The following is a description of a gene set: During acute viral infections, naïve CD8+ T cells differentiate into effector CD8+ T cells and, after viral control, into memory CD8+ T cells. Memory CD8+ T cells are highly functional, proliferate rapidly upon reinfection and persist long-term without antigen. In contrast, during chronic infections, CD8+ T cells become “exhausted” and have poor effector function, express multiple inhibitory receptors, possess low proliferative capacity, and cannot persist without antigen. To compare the development of functional memory T cells with poorly functional exhausted T cells, we generated longitudinal transcriptional profiles for each. Human Gene Set: GSE41867_DAY8_VS_DAY15_LCMV_ARMSTRONG_EFFECTOR_CD8_TCELL_DN studied in species Homo sapiens from publication Doering TA, Crawford A, Angelosanto JM, Paley MA, Ziegler CG, Wherry EJ (PMID 23159438) Genes down-regulated in CD8 T effectors at acute infection with LCMV-Armstrong: day 8 versus day 15., and this is the list of marker genes: ORM1, CNTFR-AS1, SLITRK1, KIF20A, PPFIA4, TAC4, SBK1, CGN, APOBEC2, IMPG1, IL23R (interleukin 23 receptor), AHCTF1, CCDC144BP, TDRG1, TMEM169, WDR97, TNKS, FOXF1, MBD3L2 (methyl-CpG binding domain protein 3 like 2), GMNC, TBX3, APLN (apelin), CUBN, TMEM51-AS1, DYDC1, KHDC3L, TRIM52, AQP10, LINC02223, LINC01015, IDO2, FBXO41, SPACA3 (sperm acrosome associated 3), ZFP1, ENTPD3, GJA4, ENSG00000284837, PHC1, LINC00221, ANKRD30BP2, C15orf32, TMPRSS11B, MBD3L1, FMN2, TLK2, MID1, LINC01056, ANKRD28, WFDC1, ANKFN1, PAK5, PAK3, MARCHF8, POU4F1 (NCBI Gene Id 730659), ANKRD26, VPS37D, ESRRB, KIF17, KLRG2, LINC01555, INKA2-AS1, C11orf52, ROR1, LINC00592, KRTAP2-4, CDKN3, C19orf81, TXK, FLJ30679, SLC25A2, LINC01020, SERPINA3, L1CAM, ZIC5, ANKS6, SNORD123, SCGB2A1, KCNA1, GRIK1, PRRX1, DIRC3, CDH18, ENSG00000176984, ZNF385D, CHTF18, LINC01278, ASPA, PRKCE, MTPN, ENSG00000124835, SLC6A1, FGF5, NRARP, ABCC2 (NCBI Gene Id 1244), PCCA, PDK3, KCNQ1DN, KLF17, TNFRSF19, DNA2, GLDC, ICAM5, MIR205HG, ZRANB1, GARIN1A, DCAF12, TTR, ENSG00000224090, LINC00310, H3C1, INSYN2A, POGLUT2, KLHL34, H2AC11 (H2A clustered histone 11), RCVRN, PPP1R36, CRYBB3, STRC, EFCAB3 (NCBI Gene Id 146779), VAT1L, AKR1B10, IBSP, RNF217, GNRH1, ERCC6L2-AS1, ANKRD17, ACACA, SYT7, SLC25A22, CYP17A1, NOP14-AS1, GARIN5A, PCOLCE, B4GALNT1, CASC16, CDK15, PRKCZ, OLFM3, RIBC2, EGFLAM, FOXF2, LINC01116, CFAP73 (cilia and flagella associated protein 73), IQCD, PCDH9, ALAD, NPPA, PRAP1, MC3R, CHRNA4, DIO1, HPSE, C1QTNF1-AS1, CORO2B, PATE1, GRIA1, AP1AR, ENSG00000293232, FXYD1, CREB3L1, NKX2-5, VSTM4, CCNP, CADM2, DIDO1, NEBL (nebulette), OR2W3, RRP9, FAM47B, CHIA, KRTAP4-1, ABCA3, VPS13A-AS1, ACTR3C, RXFP2, CLDN8, PTGDR, SMC5, CST1, CD7, TAF1L, ZNF418, DUSP16